Given this list of marker genes ZNF408, FZD1, STRIP2, RPS23, OPA1, NDUFB3, ABCA11P, RPL10A, SNORA7A, ZNF721, ATP6V1E2, KCNJ5, MAPK10, INTS5, MFSD14A, SNORD54, LIPE-AS1, RPS14, SLITRK3, SLC25A44 (solute carrier family 25 member 44), CSNK1D, RAB5B, RPS10-NUDT3, H2BC4, GMFB, RIBC1, FAM200A, DPYSL2, DHX58, RAB18, SLC8A3, DDX39B, SNORD43, RBM5, RPS2, NUP155, RPL17, RPL24, SF3B3, MCM3, POLH-AS1, RPL3, ZNF16, VPS51, EZH1, CSTF2T, STK3, ZNF462, SNORD84, SRSF11, RPS7, SRP19, APIP, SH2B1, H2BC11, HAR1A, ESF1, MRPL13, ANXA2, ZNF425, H2AZP3, TVP23B, ICMT, MIR1972-2, RPL37, RPL6, SNORA50C, FANCB, DPP8, RPL29, CFAP276, SMC1A, FGFBP3, NR2F1-AS1, GFM2, SMG8, FOXS1, RPL8, ZNF8-DT, RBBP4, CSE1L-DT, SNRPB, RPL32, RPS10 (NCBI Gene Id 6204), PCOLCE-AS1, RNF167, EFCAB7, PAXBP1, DMTF1, FGF7, LSM8, MOSPD2, ZMYM3, SNHG17, PGK1, HMGA2, ACYP1, RPL7, C10orf143, EPCIP-AS1, PDHX, MRPL44, CCAR1, PHIP, BAGE2, ZBTB20, SNHG9, RPL35A, SMARCD2, YEATS2, KIAA0586, TIMM9, ERVK3-1, ADAMTSL5, ALKBH1, GBA1 (NCBI Gene Id 82008), MIR3677HG (MIR3677 and MIR940 host gene), RPS15A, TP53I3, ATP5PB, DEGS1, H2AZ1-DT, PRRC2C, CERNA3, RPL39, TK1, TXNIP, CDC27, C2orf49, EIF4G3, RPL37A-DT, STX6, TMX4-AS1, TMEM79, MPV17, C19orf48P, SMG5, PCBP2, TMEM52B, ZC2HC1C, RPL5, NREP, MECOM, RNU6-1, TMEM232, NKIRAS1, BASP1-AS1, ENSG00000212175, LINC00426, MTBP, PMEL, MDM2, DNA2, DHX29, MEIS2, PUM1, ITGB3BP, SMAD4, KMT5B, RPL15, STAT6, PHF20, USP47, FLI1, C2orf49-DT, LINC00960, ZNF268, CEACAM19, ZNF398, TOX4, SNHG25 (NCBI Gene Id 105376843), CPVL, ARHGAP1, SMARCC1, RPS20, LAMTOR5, ASB15-AS1, ZNF799, ZNF317, HYCC2 (NCBI Gene Id 285172), SEC62, RPL17-C18orf32, NSA2, MFF, XPO5, PSMD1, AARS1, NUP188, DLX3, SNX16, CA5BP1, SNORD104, RPL37A, SEMA3A, YEATS2-AS1, NR2F1, UBE2M, IQCG, RPL11, ATAD3A, POLR3B, SNORD58B, MTCO3P12, HDAC8, NDUFAF5, SMCHD1, SEC31A, PDZD2, SAT1-DT, SMC4, ELAPOR1, ISLR2, RNPS1, EIF3F, PNO1, SAT1, TMEM18, WDR77, RHOQ, MIR4638 (microRNA 4638), MIR4734, ANKLE2, TNRC18, RPS18, WWP2, EMC3-AS1, DHX9 (NCBI Gene Id 3450), GOLM2, CDCA7, WDR76, RPL27, COMMD1, TGM2, RPS3, EIF4ENIF1, RPS6KB1, CCDC97, DNAAF10, KAT2A, NACA, NUTM1, IFRD1, MFF-DT, UBE2I (NCBI Gene Id 7329), NOP10, ZBTB20-AS4, AIFM2, TUBD1, RPL41, RPS4X, RIF1, KDM4A, MAP3K8, UBE3B, FANCI, DMC1, KCTD10, RCBTB2, VTI1A, HNRNPU, COG4, VEZT, RNA5SP395, ZFX, ZDHHC6, BASP1, TYK2, DHX15, ARPC5L, LUC7L3, CCT4, AFMID, RAB2B, FBXO11 (F-box protein 11), SETD5, RN7SL521P, TGS1, KLHDC9, RHOXF1P1, SNORA78, PCOLCE, BRWD3, IGFL4, SMYD2, ZNF718, SVIL, H2AZP1, E2F3, LINC02772, SLC4A5 (solute carrier family 4 member 5), EMC3 (ER membrane protein complex subunit 3), IRS1, RSBN1L, LAMTOR5-AS1, LINC02405, PSEN1, NDUFAF6, CREBZF, ARG2, SLC25A11 (NCBI Gene Id 8402), ZNF335, ARHGEF1, PRPF4, ZNF827, DDX39B-AS1, SNORD15A, VPS52, DNAJC19P1 (DnaJ heat shock protein family (Hsp40) member C19 pseudogene 1), MDGA1, TRIM41, ZNF655, ICMT-DT, HSPB9, ZFHX3, UBE3C, RPS3A, RPL36, EEF1A1, ENSG00000249236, here is a description of the gene set: species: Homo sapiens from publication Yevshin I, Sharipov R, Kolmykov S, Kondrakhin Y, Kolpakov F (PMID 30445619) Human Gene Set: ZZZ3_TARGET_GENES Genes containing one or more binding sites for (ZZZ3) in their promoter regions (TSS -1000,+100 bp) as identified by GTRD version 20.06 ChIP-seq harmonization.